Given this list of marker genes PSEN2, CLTB, ADAM10, PAK2 (NCBI Gene Id 9106), EPHA1, GIT1, EPHB1, EPHB4, NGEF, MYL9, KALRN, RAC1, LIMK1, GRIN1, EFNA3, ACTR3 (NCBI Gene Id 10096), PSENEN, MYH9, VAV2, LIMK2, SDC2, CLTCL1, EPHA2 (NCBI Gene Id 1969), AP2M1, APH1B, ARPC4, EPHA10, PSEN1, NCK2, EFNB3, PAK3, FYN, MYL12B, ITSN1, ARPC1A, PAK1, DNM1, CDC42, EPHA6, EFNA2, EFNB1, CFL1, ARHGEF28, TIAM1, MMP2, AP2B1, AP2S1, APH1A, PTK2, MYL12A, ARPC1B, ROCK1, SRC, LYN, MYH10, GRIN2B, ACTG1, EPHA5, EPHA4, SDCBP, ARPC3, EFNA1, HRAS, RASA1, MYH11, ROCK2, EFNA4, MYL6, CLTC, EPHA3, YES1, RHOA, EPHB3, EPHA7, ARPC5, CLTA, EFNA5, EPHB6, AP2A1, EPHA8, EPHB2, MMP9, ARPC2, AP2A2, ACTB, EFNB2, ACTR2, WASL, VAV3, NCSTN, MYH14, ARHGEF7, here is a description of the gene set: Human Gene Set: REACTOME_EPH_EPHRIN_SIGNALING studied in species Homo sapiens EPH-Ephrin signaling